The following is a description of a gene set: A protein complex containing at least one glycosylated protein, may be held together by both covalent and noncovalent bonds. species: Mus musculus Mouse Gene Set: GOCC_GLYCOPROTEIN_COMPLEX, and this is the list of marker genes: Sgca, Sntb2, Utrn, Sgce, Dmd, Cav3, Krt8, Gp1ba, Sgcg, Snta1, Sgcb, Dtna, Sgcd, Sntg2, Krt19, Pgm5, Sgcz, Sntb1, Flna, Sspn, Gp9, Gp5, Gp1bb, Dag1, Sntg1